The following is a description of a gene set: The conversion of a primary RNA molecule transcribed from a mitochondrial genome into one or more mature RNA molecules; occurs in the mitochondrion. species: Mus musculus Mouse Gene Set: GOBP_MITOCHONDRIAL_RNA_PROCESSING, and this is the list of marker genes: Fastk, Fastkd1, Hsd17b10 (NCBI Gene Id 15108), Trnt1, Rpusd4, Mto1, Cdk5rap1, Elac2, Trmt10c, Fastkd5, Supv3l1, Trmt5, Prorp, Tbrg4, Fastkd3, Mettl8, Mtpap, Fastkd2, Trit1, Pnpt1, Angel2